Given this list of marker genes Gjb6, Tmem63b, Pou3f4, Scn10a, Kcnq1, Ush1c, Cemip, Mir23a, Mir23b, Mir92-2, Mir467a-4, Lhfpl4, Sod2, Mir770, Mir34a, Myo1a, Scn8a, Mir27b, Mir34c, Ccdc50, Myo6, Mir222, Myo7a, Myo3a, Clrn2, Cacnb3, Htr7, Pomgnt1, Asic2, Barhl1, Ndufs4, Slc12a2, Mir467a-10, Jag2, Mir301, Cdkn1b, Mirlet7a-1, Mir30b, Ddit3, Diaph1, Mir467a-1, Kcnk4, Otof, Mir203, Chrna9, Mir25, Diaph3, Mir99b, Phf24, Alms1, Mir92-1, Mir151 (microRNA 151), Piezo2, Srrm4, Mir16-1, Myo7b, Slc1a3, Usp53, Mir409, Hoxa1, Cxcr4, Ptprq, Mir324, Npr2, Ankrd24, Axin1, Mir181c, Col11a1 (NCBI Gene Id 77655), Mbp, Sod1, Mir652, Cxcl12, Mir24-2, Coch, Mir221, Mir762, Nherf2, Nav2, Mir542, Tjp1, Serpinb6e, Sox2, Adgrv1, Marveld2, Ceacam16, Psap (NCBI Gene Id 19156), P2rx2, Mir124-2hg, Fam107b, Tbl1x, Pdzd7, Mir429, Mir140, Mir455, Mir298, Mir146b, Mir24-1, Eya4, Kcnma1, Cdh1, Spry2, Trpv1, Myo15a, Gjc3, Tlr4, Mir338, Mir361, Myo3b, Myh14, Loxhd1, Mir100, Mir29a, Atp6v0a4, Thrb, Mir107, Mir467a-8, Igf1 (insulin-like growth factor 1), Ccdc154, Mirlet7d, Drgx, Tshz3, Mir200b, Mir467a-5, Lhfpl3, Fzd4, Mir487b, Scn1a, Bsnd, Serpinb6c, Hexa, Mir148a, Ucn, Tnf, Cdkn2d, Nherf1, Rest, Lrig2, Mir331, Mir182, Mir125b-2, Eps8l2, Mir467a-9, D130043K22Rik, Ntrk1, Mir17, Cdh23, Wfs1, Slitrk6, Mir532, Il18, Atp2b2, Tmie, Mcoln3, Tmprss3, Espnl, Dcdc2a, Mir130a, Mir124a-1hg, Six1, Mir31, Epyc (epiphycan), Mir200c, Pawr, Elmod3, Mirlet7g, Tecta, Large1, Mir200a, Tprn, Trpa1, Grin2b, Pkhd1l1 (NCBI Gene Id 192190), Mir181d, Tmc2, P2rx4, Homer2, Chrna5, Stx4a, Strc, Mir467a-3, Slc26a5, Enpp1, Mir676, Mir744, Ifng, Pgap1, Mir20b, Mir181a-1, Grm8, Hpn, Mir20a, Col1a1, Fbxo11, Mir149, Mir205, Mir326, Snai2, Gsdme, Minar2, Htr2a, Otog, Mir93, Atp8b1, Tbx18, Tmc7, Chd7, Tmc1, Myc, Scn9a, Mir148b, Lhfpl5, Whrn, Wdr1, Mir16-2, Mpv17, Grin2d, Aqp4, Tub (TUB bipartite transcription factor), Mir711, Ppip5k2, Gjb2, Tmtc4, Kcna1, Pou4f2, Itga2, Pou4f3, Map1a (microtubule-associated protein 1 A), Mir383, Tmem120a, Ano1, Mir22, Cabp2, Mkks, Fyn, Espn, Mir706 (microRNA 706), Spns2 (NCBI Gene Id 216892), Nipbl, Mir296, Grm7, Otos, Cntn5, Clrn3, Mir467a-7, Pcdh15, Mir434, Ror1, Tspear, Clic5, Grxcr2, Hexb, Kcnq3, Scn11a, Atp6v1b1, Mir152, Sobp, Triobp, Bace1, Mir125b-1, Asic3, Cdc14a, Serpinb6d, Mir193b, Mir467a-6, Tmem87a, Mir183, Mir106b, Mir199a-1, Mir322, Serpine2, Mir146, Mir501, Gpx1, Mir467a-2, Tomt, Mir130b, Mir199a-2, Get1, Mir1195, Mir671, Sptbn4, Grap, Mir141, Tfap2a, Col11a2, Mir181a-2, Ush1g, Mir451a, Mir206, Mir96, Pjvk, Mir30d, Grin2a, Serpinb6b, Ripor2 (RHO family interacting cell polarization regulator 2), Mir491, Mir674, Clrn1, Col6a1, Slc4a7, Kcnk2, Slc17a8, Rpl38, Alg10b, Casp3, Mir29b-1, Mir351, Serpinb6a, Ush2a, Rab3a, Col2a1, Mir199b, Otoa, Mir195a, Kit, Otogl, Kcnq4, Kcnq2, Scarb2, Fgfr1 (fibroblast growth factor receptor 1), Mir29b-2, Chrna10, Lrig1, Crym (crystallin, mu), Mir329, Mir345, Mir497, Slc52a3, Grxcr1, Chrnb2, Mir28a, Mir342 (NCBI Gene Id 723909), Tbx1, Cacna1d, Lrp2, Tectb, here is a description of the gene set: The series of events required for an organism to receive a sensory mechanical stimulus, convert it to a molecular signal, and recognize and characterize the signal. This is a neurological process. species: Mus musculus Mouse Gene Set: GOBP_SENSORY_PERCEPTION_OF_MECHANICAL_STIMULUS